Given this list of marker genes C5, MIR128-1, BCR, STAP1, CNN2, EMILIN1, MMP28, CD200, MIF, CD200R1, CYP19A1, DDT, SLAMF8, MIR24-1, here is a description of the gene set: Any process that stops, prevents or reduces the frequency, rate or extent of macrophage migration. Human Gene Set: GOBP_NEGATIVE_REGULATION_OF_MACROPHAGE_MIGRATION species: Homo sapiens